The following is a description of a gene set: studied in species Homo sapiens Neighborhood of CDC10 Human Gene Set: MORF_CDC10 Neighborhood of CDC10 NULL in the MORF expression compendium, and this is the list of marker genes: ILF2, PSMA1, SPG11, TIAL1, XPO6, NSA2 (NSA2 ribosome biogenesis factor), SFSWAP, CDK2, ARL2BP, VAMP3, LANCL1, TERF2IP, POLR2A, NUP188, SUGP2, TAX1BP1, ASH2L, ZNF131, SUMO2 (NCBI Gene Id 6613), CNP, CHUK, FOXJ3, PIN1, CAPZA1, TUBA3C, SMC5, SNRNP200, EIF3M, SEPTIN7, TACC1, KDM3B, COPS2, XPO1, TIMM17A, GTF2A2, ARPC3, PRKDC, HNRNPA2B1 (NCBI Gene Id 3181, heterogeneous nuclear ribonucleoprotein A2/B1), TCEA1, XPO7, SAFB, VDAC3, AATF (NCBI Gene Id 26574), CALM2, CUL2, VPS26C, PRKRA, SHOC2, HMGB1, PHIP, CLSTN1, DUT, DDB1, RTCB, SRRM1, TFAP4, SRSF11, LRPPRC, DDX46, DHX38, PGK1, POM121, GNB1, TRRAP, LBR, HNRNPK, PRKAG1, IMMT, NONO, PLIN3, CASC3, HNRNPH2, CCT4 (chaperonin containing TCP1 subunit 4), BMS1, CS, STK24, SUN2, PSME4, RPL22, ATP11B, STARD7, ZPR1, HSPA8, KXD1, PTP4A2, CAPRIN1, TCOF1, NAE1, SUMO4, CDK11A, TERF1, PRPF8, SERP1, USP1, DNAJC8, OXA1L, ANAPC5, TXLNA, AFG3L2, AFF1, CTDNEP1, SMNDC1, CRKL, EIF1AX, TP53BP1, ZC3H15, RNPS1, HNRNPL, AP3D1, RBM6, ADD1, DIAPH1, RNF44, SDR39U1, ARIH2, EIF4A2, RNGTT, KHDRBS1, XRCC5, MORC3, DEK, POLR2C, PUM2, BRD8, ARHGEF7, MCFD2, NACA, ATXN2L, RFC1, PITPNM1, ACAP2, HNRNPD, HNRNPH3, TMEM123, KRAS (KRAS proto-oncogene, GTPase), YWHAQ, GAK, RPA2, FRG1, PPP2CA, NAP1L4, SSB, CNOT1, DYRK2, SEC63, HNRNPR (NCBI Gene Id 10236)